The following is a description of a gene set: species: Mus musculus Genes predicted to be targets of miRBase v22 microRNA mmu_miR_301a_5p, mmu_miR_301b_5p in miRDB v6.0 with MirTarget v4 prediction scores > 80 (high confidence targets). Mouse Gene Set: MIR_301A_5P_MIR_301B_5P from publication Chen Y, Wang X (PMID 31504780), and this is the list of marker genes: Fcna, Itgb2, Rab1a, Xpc, Cemip, Srf, Sstr1, Tspan18, Tpp2, Xpo6, Nfyb (NCBI Gene Id 18045), Nr2c2, Wdr76, Rassf3, Nipal1, Rras2, Zfp626, Rspry1, Lmln, Narf, Zfp12, Ptprb, Supt7l, Unc5d, Ptgfr, Dixdc1, Arvcf, Elk1, Atp2a3, Ly6c1, Ifi27l2b, Spcs2, Nomo1, Cdin1, Bnc2, Abca5, Tmem88, Foxj2, Eif2s2, Leap2, Pnpla5, Clcn1, Scarb2, Tmem132b, Prps2, Npas3, Vamp4, Stx3, Traf3, Erg, Set, Pitpnb